The following is a description of a gene set: Any process that results in a change in state or activity of a cell or an organism (in terms of movement, secretion, enzyme production, gene expression, etc.) as a result of detection of, or exposure to, an increase in the concentration of salt (particularly but not exclusively sodium and chloride ions) in the environment. Human Gene Set: GOBP_HYPEROSMOTIC_SALINITY_RESPONSE studied in species Homo sapiens, and this is the list of marker genes: AKR1B1, TRPV4, MICU1 (NCBI Gene Id 51415), FBP1, ABCB1, EFHD1, XRCC6, FXYD2, SLC25A23, LETM1